Given this list of marker genes SPRED1, NFAM1, TMBIM1, TCEAL1, APPL2, EHBP1L1, TSC22D1, PLA2G15 (NCBI Gene Id 23659), CRYZL1, PNP, ZEB2, NIBAN2, ABCE1, GNA15, RNASE4, TTPA, ZNF202, CERS2 (ceramide synthase 2), TYROBP, OTOS, CD180, ARMCX4, MPHOSPH10, ARL1, ARRB2, PSMA1, CLEC4E, TESC, CD44, CCND1, NCF1, RCN3, CD9, TGFBR2, LGALSL, HES5, VAMP5, CST7, ORC2, GCSAM, FHOD3, RAMP2, B4GALT6, CD81, FCGR2B, LRRK1, SOCS5, DNMT3B, MT2A, CD68, CHCHD4, AQP1, ANXA1, UBE2E2, ATP6V0A2, IGDCC4, VIM, FGD2, NEK6, VAMP3, CDH17 (NCBI Gene Id 1015), ZNF22, ASNSD1, RNF149, ALOX15, KLF4, GRB10, EPS8, DMAC2L, P2RY14, UAP1L1, GNG2, PRCP, PRDM5, DOCK7, SKAP2, ARHGAP21, SWAP70, CKAP4, TMEM119, SLC24A3, MYO1C, SLC4A1AP, GIMAP7, MEIS1, SEPTIN2, NLGN2, GK, COASY (NCBI Gene Id 80347), PLSCR1 (NCBI Gene Id 5359), LMO2, BTK, CDCA7L, NDN, RNH1, NFU1, HLA-C, GGH, GCLC, BCL3, RAB43, CD93, S1PR1, RFLNB, TBC1D24, TGM1, NIPSNAP3A, TOP1MT, THEMIS2, LTF, IL10RB, IL11RA, RIPOR1, FBXO33, ADD3, YAF2, ZNF768, HYCC1, C11orf54, PLA2G4A (phospholipase A2 group IVA), NCOA4, FCRL1, LPIN2, SLC28A2, PCYT1A, FLNA, TRIM13, SYPL1, STK26 (NCBI Gene Id 51765), SIRT3, FADS3, SLCO3A1, PKIB, SMAD7, CEBPB (NCBI Gene Id 90277), PTGER2, PLXNB2, CCR8, C1orf174, UTP20 (UTP20 small subunit processome component), TSPAN33, IKBIP, GSPT2, MARVELD1 (NCBI Gene Id 83742), PDIA5, FH, TTC39C, STX3, ZNF280C, LDLRAP1, OSBPL5, PDGFRB, OTULINL, NFIX, PAK1, THOC1, CSF1R, FES, ADAMDEC1, ESAM, MAP2K3, MCOLN3 (NCBI Gene Id 55283), SLC16A7, RPP40, GLUD1, TIFA, CD300A, SCCPDH, MEF2C, FASTKD1, THNSL1, EHD4, TNFRSF21, HHEX, FAM111A, EPDR1, SYNCRIP (NCBI Gene Id 10492), PROCR, C1orf54, RHOQ, SERPINB1, TTC39B, BIRC3, C6orf89, CFP, C9orf72, DOK2, COL9A3, ENO3, CD33, TSPAN4, PCTP, SASH1 (NCBI Gene Id 387570), TF, GYS1, IL18R1, IDE, CLEC10A, KIT, SERF1A, here is a description of the gene set: Genes up-regulated in comparison of thymic progenitors versus fetal DN3 thymocytes. Development of T-cells provides a unique opportunity to study cell-fate determination due to the accessability and the well defined stages of developmental stages. In order to understand the genetic programs underlying fetal and adult T‑cell fate specification we subjected highly purified fetal and adult T-cell progenitor populations to a genome‑wide transcriptional analysis. The aim was to identify molecular elements that govern T-cell fate specification as a whole but ultimately to isolate elements that were specific for a given population in a specific developmental window. from publication Belyaev NN, Biró J, Athanasakis D, Fernandez-Reyes D, Potocnik AJ (PMID 22581009) studied in species Homo sapiens Human Gene Set: GSE24142_EARLY_THYMIC_PROGENITOR_VS_DN3_THYMOCYTE_FETAL_UP